Given this list of marker genes SGPP1, PLEKHA8, VAPA, OSBP, ABCB1, CLN3, ABCA2, GLTP, ABCA13, PLEKHA8P1, PLTP, CERT1, CPTP, ABCB4, ABCA12, GLTPD2, MTTP, PSAP, here is a description of the gene set: Human Gene Set: GOBP_CERAMIDE_TRANSPORT The directed movement of ceramides into, out of or within a cell, or between cells, by means of some agent such as a transporter or pore. Ceramides are a class of lipid composed of sphingosine linked to a fatty acid. species: Homo sapiens